The following is a description of a gene set: The process that gives rise to the cerebellar cortex. This process pertains to the initial formation of a structure from unspecified parts. The cerebellar cortex is a thin mantle of gray matter that covers the surface of each cerebral hemisphere. It has a characteristic morphology with convolutions (gyri) and crevices (sulci) that have specific functions. Six layers of nerve cells and the nerve pathways that connect them comprise the cerebellar cortex. Together, these regions are responsible for the processes of conscious thought, perception, emotion and memory as well as advanced motor function. species: Homo sapiens Human Gene Set: GOBP_CEREBELLAR_CORTEX_FORMATION, and this is the list of marker genes: NRXN1, SLC25A46, RORA, CDK5, LHX5, DLL1, LDB1, GBA1, TTLL1, WHRN, HERC1, FAIM2, FOXP2, KNDC1, GRID2, AGTPBP1, PROX1, CBLN1, ATP7A, SKOR2, LHX1 (LIM homeobox 1), CEND1, PTPN11, MAP2K1, OPHN1, TTC21B, WNT7A